Given this list of marker genes PRKAA1, BCL2, CTNNB1, IGF2, TWIST1, SHOX2, MEGF10, MYOD1, MYF6, TGFB1, USP19, YBX3, MYOG, MTM1, FLOT1, NACA, MYF5, LMOD3, DLL1, MEF2C, WNT3A, SHH, ACTN3, CDON, WNT10B, here is a description of the gene set: studied in species Homo sapiens Any process that modulates the frequency, rate or extent of skeletal muscle tissue development. Human Gene Set: GOBP_REGULATION_OF_SKELETAL_MUSCLE_TISSUE_DEVELOPMENT